Given this list of marker genes Anapc1, Tubb4b (tubulin, beta 4B class IVB), Tubb2a, Kntc1, Cenps, Cenpk, Tuba1b, Mapre1 (NCBI Gene Id 99354), Zw10, Cenpo, Ube2s, Smc1a, Cenpp, Zwilch, Mad2l1, Spc24, Ppp2r5d, Ndel1, Smc3, Psmd6, Psmb2, Bub3, Nup85, Nup37, Psma1, Ube2e1, Anapc16, Anapc7, Psmc1, Bub1, Kif2a (kinesin family member 2A), Rcc2 (regulator of chromosome condensation 2), Ppp2ca, Cenpf, Anapc11, Psmb7, Cenpe, Rangap1, Wapl, Tuba8, Ahctf1, Seh1l, Psma7, Clasp1, Ppp1cc, Hdac8, Ckap5, Plk1, Cdc23, Psmd12, Dync1li2, Ube2d1, Ppp2r5b, Nup160, Clip1, Tubb4a, Uba52rt, Sgo2a, Stag1, Psmb5, Pmf1, Cenpm, Rad21, Cdc20, Nudc, Adrm1, Spc25, Psmb1, Psmc4, Psmd3, Spdl1, Anapc15, Cdc27, Anapc5, Stag2, Ppp2r1b, Rps27, Nsl1, Tubb2b, Dync1h1, Uba52, Pds5a, Cdc26, Psmb3, Cenph (NCBI Gene Id 93823), Ska2, Psmd14, Nde1, B9d2, Ppp2r1a, Bub1b, Cdca8, Cdc16, Zwint, Espl1, Mad1l1, Sgo1, Dynll2, Tubb1, Taok1, Dynll1, Aurkb, Nup43, Cenpc1, Cenpa, Dync1i1, Kif2c, Rps27rt, Cenpl, Psma6, Cenpt, Tuba1c, Psmd7, Tuba3a, Nup98, Anapc2, Kif18a, Ndc80, Psmd1, Rps27a (NCBI Gene Id 78294), Cenpq, Psmd2, Psmb4, Tuba1a, Psmc3, Clasp2, Nup107, Dsn1, Sec13, Dync1li1, Pds5b, Psma2, Tuba4a, Pafah1b1, Ppp2r5e, Psma4, Ubb, Psmd11, Psmc5, Nup133, Psmc6, Xpo1, Cenpi, Anapc10, Ube2c, Ppp2cb, Dync1i2, Tubal3, Cdca5, Tubb3, Mis12, Ercc6l (NCBI Gene Id 260357), Ska1, Nuf2, Ubc, Psmd8, Psmb6, Ranbp2, Psmd13, Ppp2r5a, Kif2b, Anapc4, Psma3, Itgb3bp, Cenpn, Incenp, Psma5, Cenpu, Tubb6, Pttg1, Psmc2, Ppp2r5c, Tuba3b, here is a description of the gene set: Separation of Sister Chromatids species: Mus musculus Mouse Gene Set: REACTOME_SEPARATION_OF_SISTER_CHROMATIDS